Given this list of marker genes SASH1, ZYG11B, LYN (LYN proto-oncogene, Src family tyrosine kinase), APTX, ZNF124, HLF, ERVFRD-1, DNAJB4, U2SURP, PSMD12, TMEM80, OAS2, CORO1C, S100Z, SH2D7, G6PC3, PLAT, PDE8A, SMAD6, ARHGAP28, RTCA, GDF6, UBE2E3, CDYL2, AZIN1, SV2C, CXCL12, INS-IGF2, ZFP3, FAM120C, TMEM260, FSHR, SPCS1, HDDC3 (NCBI Gene Id 374659), PRDM5, NEDD4, GIPC3, FBXO33 (NCBI Gene Id 254170), C19orf44, PDE3A, IRF2, MARCKS, here is a description of the gene set: from publication Chen Y, Wang X (PMID 31504780) species: Homo sapiens Human Gene Set: MIR1298_3P Genes predicted to be targets of miRBase v22 microRNA hsa-miR-1298-3p in miRDB v6.0 with MirTarget v4 prediction scores > 80 (high confidence targets).